The following is a description of a gene set: Mouse Gene Set: REACTOME_SNRNP_ASSEMBLY snRNP Assembly studied in species Mus musculus, and this is the list of marker genes: Wdr77, Nup214, Nup42, Clns1a, Aaas, Snrpf, Pom121, Ddx20, Snupn (NCBI Gene Id 66069), Nup85, Snrpg, Nup35, Gemin5, Nup205, Tgs1, Nup155, Tpr, Nup160, Snrpd2, Nup133, Sec13, Nup88 (nucleoporin 88), Gemin2, Snrpd1, Gemin4, Nup98, Prmt5, Rae1, Nup37, Seh1l, Nup93, Ranbp2, Nup58, Nup153, Nup54, Snrpb, Nup107, Smn1, Nup43, Gemin6, Snrpe, Nup210, Ndc1, Snrpd3, Nup62, Nup50, Gemin7, Gemin8, Nup188